Given this list of marker genes Calhm3, Shoc2, Slc25a4, Calhm6, Slc35b3, Cd47, Ank, Slc25a25 (solute carrier family 25 (mitochondrial carrier, phosphate carrier), member 25), Lrrc8a, Slc19a1, Adcy10, Lrrc8b, Calhm4, Slc35b2, Calhm5, Slc25a17, Gjb1, Lrrc8d, Panx1, Slc25a24, Lrrc8e, Slc25a51, Slc25a41 (solute carrier family 25, member 41), Slc35b1, Gja1, P2rx7, Slc25a31, Calhm2, Calhm1, Slc17a9, Abcc4, Abcc6, Slc25a5, Slc25a23, Slc25a42, Abcc5, Slc46a2, Slc25a54, Slc25a47, Lrrc8c, here is a description of the gene set: The directed movement of a purine nucleotide, any compound consisting of a purine nucleoside esterified with (ortho)phosphate, into, out of or within a cell. species: Mus musculus Mouse Gene Set: GOBP_PURINE_NUCLEOTIDE_TRANSPORT